Given this list of marker genes Hmgcll1, Aacs, Bdh2, Acss3, Bdh1, here is a description of the gene set: electronically inferred by orthology from the curated human pathway This event has been computationally inferred from an event that has been demonstrated in another species.<p>The inference is based on the homology mapping from PANTHER. Briefly, reactions for which all involved PhysicalEntities (in input, output and catalyst) have a mapped orthologue/paralogue (for complexes at least 75% of components must have a mapping) are inferred to the other species. part of: Ketone body metabolism species: Mus musculus Reactome Pathway: Synthesis of Ketone Bodies